The following is a description of a gene set: Anterior open-bite malocclusion Anterior open bite is a malocclusion characterized by a gap between the anterior teeth (incisors), that is, by a deficiency in the normal vertical overlap between antagonist incisal edges when the posterior teeth are in occlusion. Human Gene Set: HP_ANTERIOR_OPEN_BITE_MALOCCLUSION species: Homo sapiens, and this is the list of marker genes: GNAI3, GPR68, ENAM, FAM83H, ITGB6, MMP20 (NCBI Gene Id 9313), ATP6V1B2, KCNN3, AMELX, BMP2, DSPP, KLK4, RELT, KCNH1